The following is a description of a gene set: species: Homo sapiens Neighborhood of RAD21 RAD21 homolog (S. pombe) in the GCM expression compendium Neighborhood of RAD21 Human Gene Set: GCM_RAD21, and this is the list of marker genes: RAD21, NAE1, HCFC1, NONO, TCEA1, CTCF, SRSF2, SRSF4, HMGN1, HTATSF1, BCLAF1, SET, NCL, KHDRBS1, TPR, SUMO2, LRPPRC (NCBI Gene Id 10303), ILF2, YWHAZ, SUMO1, APEX1, HNRNPA1, HNRNPU, NAP1L1, TCP1, COPS5, PCBP1 (NCBI Gene Id 5093), MAZ, HNRNPM, YWHAQ, PSMD11, TRA2B, DDX5, EIF4G2, DYRK1A, WAPL, SRP14